Given this list of marker genes Phf6, Tanc1, Jph3, Zfp609, Serpine2 (NCBI Gene Id 20720), Sdad1, Slc1a4, Elovl5, Potefam3a, Myrf, Prkx, Arhgap44, Slc25a20, Lonrf1, Prpf3, Chd1, Ermp1, Prrx1, Tacc1, Rab2a, Arg2, Fam78a, Lpin1, Elapor2, Atp8a1, Rab5b, Selenok, Klhl42, Srek1, Zfp706, Osbp, Cd9, Map2k4, Gatad2a, Rela, Edem1, Lrrc58, Prr5l, Slc10a7, Sc5d, Foxc1, Stk24, Fbxo28, Slc40a1, Stk36, L1cam, Magea10, Pdcd6, Negr1, Itga6, Nkain2, Zbtb39, Rsbn1, Pkn2, Zfp318, Tm6sf1, Fhip1a, Casc3, Rab6a, Aff1, Pcmtd2, Selenos, Golga1, Gnpda2, Tmem154, Nr3c2, Spag16, Lrch1, Hs6st2, Spry1, Mapre1, Socs6, Plekha7, Dennd1b, Neurod2, Ell2, Hipk3, Cutc, Srsf6, Rock2, Tmem129, Snx30 (sorting nexin family member 30), Lrch2, Tlcd4, Rab34, Zfp882, Mon2, Phf20l1, Dag1, Erc1, Csrnp3, D16Ertd472e, Cacnb4, Mylk4, Zdhhc3, Epn2, Nav2, Pcdh8, Dmxl2, Klf4, Kctd12, Clock, Potefam3b, Pik3r1, Etv1, Sigmar1, Col4a1, Pitpnm3 (NCBI Gene Id 327958), Mapk14, Epha3, Magt1 (magnesium transporter 1), Arf3, Nol4, Sult1b1, Marchf8 (membrane associated ring-CH-type finger 8), Zfp869, Efcab14, Ppp4r3b, Gins3, Osbpl3, Acaa2, Sp1, Pclo, Clip4, Camk4, Nova1, Ddx31, Btbd10, Arhgef4 (NCBI Gene Id 241052), Cbln4, Cert1, C1ql3, En2, Katnbl1, Slc38a2, Ist1, Pakap, Abhd17b, Mylip, Chp1, Spry2 (sprouty RTK signaling antagonist 2), Erbin, Vsnl1, Hmgxb4, Pik3c2a, Lpcat3, H2az1, Tarbp1, Crebrf, Cers2, Kdelr1, Tulp4, Zfx, Actr1a, Igf2r, Sh3bp5l, Usf3 (upstream transcription factor family member 3), Zfp236, Vangl1, Txlna, Tex26, Ptbp3, Gna13, Nek9, Sorcs2, Nexmif, Pgrmc2, Arpc5, Ccdc6, Ezh2, Sash1, Stimate, Kpna1, Usp9x, Gabra6, Emp2, Cpne3, Cdc14b, Frmd6, Tfdp2, Tex261, Jund, Zfhx4, Zfp503, Fzd4, Prr14l, Rfx3, Cadps, Selenoi (selenoprotein I), Cep350, Tmem134, Ark2c, Glud1, Myadm, Arhgap1, Fam98a, Cd276, Creb1, Rcor1, Sema3d, Runx2, Wdr41, Surf4, Zfp608, Csgalnact1, Map7, Zmat3, Pgap1, Dicer1, Prkd1, Ptpn1, Nckipsd, Ptpn12, Ro60, Ahcyl1, Wipf2, Setd7, Tal1, Cdon, Grm4, Larp1, Chst1, Cep57l1, Zfyve16, Ramp1, Angpt1, Kcnq5 (potassium voltage-gated channel, subfamily Q, member 5), Sp2, Mtmr12, Akt2, Ncam1, Rnf11, Lcp1, Slitrk6, Fbxo30, Foxq1, Stt3a, Rpia, Slc50a1, Tnrc6b, Gm9758, Mboat2, Cdk17, Rnpepl1, Sos1, Rnf216, Trpc5, 2210408I21Rik, Litaf, Cpne8, Ppp1r3e, Kcnq2, Rnf144a, Mtx3, Sec22a, Parp16, Apln, Slc31a2, Galnt1, Tceanc, Gpr37, Vps4b, Farp1, Uggt1, Cnot9, Nfib, Fkbp1b, B4galt1, Gabra5 (gamma-aminobutyric acid type A receptor subunit alpha 5), Ulk2, Slbp, Fry, Bmpr1a, Rala, Bmp6, Papola, Cotl1, Cdc37l1, Nr1d2, Lemd3, Rbms1, Antxr2, Cask, Septin10, Ppargc1a, Fam222b, Gli3, Cdk6, Snx6, Ppp2r2a (NCBI Gene Id 71978), Rcan2, Kifap3, Chsy1, Neurl1b, Piezo2, Slc35b2, Klre1, Abr, Myo10, Amer2, Pde3b, Trim14, Wasf1 (NCBI Gene Id 83767), 9330159F19Rik, Anxa7, Ccdc50, Bahd1, Amotl1 (angiomotin-like 1), Atp6v0a2, Rrbp1, Nrp2, Neurod1, Alcam, Miga1, Calm2 (calmodulin 2), Magi1 (NCBI Gene Id 78178), Fsd1l (NCBI Gene Id 633268), Phf14, Ttl (tubulin tyrosine ligase), Dsel, Usp14, Peg3, Pak5, Oxsr1, Stk38, Ormdl3, Enox1, Siae, Stag1 (STAG1 cohesin complex component), Pi4k2a, Tm9sf1, Acbd3, Bach2, Fam131b, Slc25a13, Atf2, Med26, Capn2, Adcy1, Akip1, Uba6, Spin1 (spindlin 1), Bmp2k, Prpf40a, Kcnh8, Snx18, Rb1, Dennd4c, Rwdd4a, Ttll9, Acadvl, Gzf1, Triobp, Paqr5, Ogfod3, Chsy3, Csmd1, Dctn4, Rabgef1, Pde2a, Rbms3, Map1b, Mrtfb, Sema6d, Frmd4a, E2f6, Prtg, Irf2bp2, Adra2a, Slc16a1, Ryr3, Flot2, Fam219b, Rufy2, Gabra3, Creb5, Raf1, Sema6a, Anxa11, Tra2a, F11r, Ap3m1, Myh9, Rnf103, Slc36a2, Miga2 (NCBI Gene Id 99073), Aida, Fermt2, Tor1aip2, Potefam3e, Pabir2, Btrc, Itpr3, Glcci1, Hbp1, Morc4 (microrchidia 4), Mapk4, Sugt1, Vat1l, Cbx2, Cnn3, Apbb2, Phtf2, Hdac9, Pcnx1, Yipf6, Napb, Majin, Plekhm3, Ssb, Tbr1, Lrrc49, Zcchc14, Plxnb2, Serinc2, Dusp22, 0610030E20Rik, Tspoap1, Cbfb, Lpp, here is a description of the gene set: studied in species Mus musculus Mouse Gene Set: MIR_7092_5P from publication Chen Y, Wang X (PMID 31504780) Genes predicted to be targets of miRBase v22 microRNA mmu_miR_7092_5p in miRDB v6.0 with MirTarget v4 prediction scores > 80 (high confidence targets).